Given this list of marker genes YWHAH, NR4A2, STAT3, NR4A1, NR4A3, ETS2, NCOR2, STAT5B, NRIP1, CEBPB, SMAD3, FKBP4, TACC1, FLT3, here is a description of the gene set: Human Gene Set: GOMF_NUCLEAR_GLUCOCORTICOID_RECEPTOR_BINDING Binding to a nuclear glucocorticoid receptor. species: Homo sapiens